Given this list of marker genes CLCNKB, KCNJ1, CYP27B1, WNK1, KLHL3, WNK4, CLCNKA, MAGED2, BSND, SLC26A3, SLC12A1, CUL3, here is a description of the gene set: Abnormal blood chloride concentration species: Homo sapiens Human Gene Set: HP_ABNORMAL_BLOOD_CHLORIDE_CONCENTRATION An abnormality of chloride homeostasis or concentration in the body.